The following is a description of a gene set: studied in species Homo sapiens Human Gene Set: GOMF_PHOSPHATIDYLCHOLINE_FLOPPASE_ACTIVITY Catalysis of the movement of phosphatidylcholine from the cytosolic to the exoplasmic leaflet of a membrane, using energy from the hydrolysis of ATP., and this is the list of marker genes: ABCG1, ABCA7, ATP10A, ATP8B1, ATP8B2, ABCB4, ABCA1, ABCB1